Given this list of marker genes ATF4, PROX1, TBC1D20, CRYGB, CRYAA, EPHA2, ABI2, here is a description of the gene set: studied in species Homo sapiens The process in which the structures of a lens fiber cell are generated and organized. This process occurs while the initially relatively unspecialized cell is acquiring the specialized features of a lens fiber cell. A lens fiber cell is any of the elongated, tightly packed cells that make up the bulk of the mature lens in a camera-type eye. Human Gene Set: GOBP_LENS_FIBER_CELL_MORPHOGENESIS